The following is a description of a gene set: Human Gene Set: GOBP_REGULATION_OF_VESICLE_MEDIATED_TRANSPORT Any process that modulates the rate, frequency, or extent of vesicle-mediated transport, the directed movement of substances, either within a vesicle or in the vesicle membrane, into, out of or within a cell. studied in species Homo sapiens, and this is the list of marker genes: CCL2, CACNB4, PTPN1, HFE, SNAPIN, ATG5, RIMS2, LYN, APOA1, BVES, DNAJC5, TBC1D5, CASK, RAC2, HLA-F, FCGR1BP, CADPS, SCFD1, IL13, VAMP7, ARAP1, APLNR, C4B, SYT10, MIR185, RAPGEF4, HMGB1, LGALS3, REST, CPLANE2, CCDC32, CBLL1, RAB3C, PRKCA, GAS6, ATP13A2, CALY, AP1G1, HYAL3, SYT6, PRAM1, MCTP1, STAT3, TFR2, DTNBP1, SFRP4, DRD2, DOC2A, LAMP1, STX1A, ARF6, CPLX2, SNF8, DRD4, TUB, ADGRE2, PYCARD, SDC4, UBQLN2, RALA, PIP4P2, PCSK9, BET1L, GPR151, BCR, MSN, FGA, PTX3, ANKRD13A, CNN2 (NCBI Gene Id 1265), ANO6, MYO18A, FCN1, UNC13D, GATA2, APOC1, FCGR2A, PACSIN1, ANXA13, ANKRD27, SIRPB1, TAMALIN, RACK1, C2, RUFY1, DOCK2, PFN2 (NCBI Gene Id 85837), TLR2, PLA2G5, PLCG2, GPC3, KCNB1, STXBP3, EGF, FMR1, RAB31, SV2C, RAB15, TSC2, FGR, APPL1, LETMD1, RAB7A, NR1H2, TOR1A, ATAD1, DLL1, ABCA7, SYT12, GSG1L, AP2S1, CD300A (CD300a molecule), ADIPOQ, PLLP, AP2B1, SH3GL2, EHD1, RAB11A, MAPK3, CLASP2, PDCD6IP, PGAP1, SOD1, RAB5A, PRKCG, SV2B, MIR205, C9orf72, PICK1, ITGB2, CAMK1D, F2RL1, PLD1, PTPN23, ATP2C1, EHD4, SNX33, PRKN, RUFY2, GIT1, RAB4B, CHMP2A, FLOT1, ARHGAP1, SNX4, LGI3, CLEC7A, TSG101, RUFY4, RAB11B, ANGPT1, S100A10, MBTPS1, SNX17, PLA2G3, YIPF5, MIR199A1, CYBA, CD177, MAP2K2, ARRB2, CDK5, RAB29 (RAB29, member RAS oncogene family), RPH3A, SLC11A1, GRIK5 (glutamate ionotropic receptor kainate type subunit 5), ATP2A2, SYT7, PICALM, APOA5 (NCBI Gene Id 93561), ITGA2, IFNG, PPP3CB, NSF, STAM, SYT3, SPACA3 (sperm acrosome associated 3), LILRB1, SPHK2, EXPH5, USH1G, VEGFA, PCLO, LYAR, RAB4A, ANKRD13B, FCER1G, LYPLAL1, CLASP1, ACTB, ITGAM, PLS3, RAP1A, PSEN1, DYNC1LI1, PPT1, GRIPAP1, STAP1, ANKFY1, FCGR1A, LRRTM2, STXBP5, SEPTIN4, USP7, RABGEF1, WDR44, LRPAP1, LRSAM1, DLG4, SEPTIN1, COLEC11, CCR7, FGB, CPLX3, VAMP2, GAS1, EIPR1, RINT1, APOC3, ARHGAP8, CDC42, NEU3, TBC1D4, RUBCN, ATXN2, SGIP1, CADPS2, ATP9A, BIN1, ARFIP1, FCGR2C, VPS28, DKK1, STXBP1, STXBP6, DYSF, IL2RG, LMAN2, TGFB1, UNC119, SNX3, VPS18, HPCA, COMMD1, RSC1A1, NEDD4L (NEDD4 like E3 ubiquitin protein ligase), VAMP8, USP46, FBXL20, PREPL, ZNRF2, DOC2B, TGM2, AZU1, APELA, SLC4A8, ROCK1 (Rho associated coiled-coil containing protein kinase 1), STON1, SIRPA, SYN1, CHMP3, ABCA13 (ATP binding cassette subfamily A member 13), WNT5A, CALR, RSPO1, ARRB1, GAB2, IL15RA, DAB2, SLC30A8, SCRIB, NCKAP1L, CD160, VPS4B, MDM2, CD22, PPFIA2, RNF139, CLIP3, APOA2, SUSD4, RAP1B, CNST, RAB27B, MIR183, ARC, GNAI2, RAB2B, BICD1, LPAR1, STX18, ACTG1, STX4, MTMR2, ZDHHC2, TF, MTMR4, RNF220, CD14, MICAL1, GATA1, MIR17, EZR, SYTL4, ZNRF1, IL4 (NCBI Gene Id 3565), SYT1, SYT9, PPP3CC, WASL, APOE, DENND10 (NCBI Gene Id 404636), SYT8, CALM3, EHD2 (EH domain containing 2), DNAJC13, AHI1, GH1, RAB3D, CFP, SYNJ2BP, CLU, RAB11FIP3, USE1, CCL21, ABL2, EEF2K, USP6, GREM1, SMPD3, AXL, TRPV6, NPY, RAB21, SYT4, OPHN1, PRKAR1B, PARK7, SEPTIN5 (NCBI Gene Id 5413), LRRK2, SIRPG, RIMS3, RABEP1, CSK, CDH13, CD63, AAK1, SPHK1, ARHGDIA, ABCA2, LDLRAP1 (NCBI Gene Id 81862), APP, SYK, RAB3B, ITGAV, AKAP5, RAB3GAP1, CORO1A, PIK3CB, RAC1, CSPG5, PPP3CA, VAC14, MERTK, NLGN1, MIR20A, RAP1GAP, WNT3A, MAGI2, PLA2G4E, CDK5R2, SYT5, SCARB1, SCRN1, CD84, NOTCH1, EPHA3, PLSCR1, ZP3, MIB1, MAPK1, BAIAP3, SNX9, SMPD1, PTPRJ, PACSIN2, LRRTM1, ARPC3, HCK, CD47, ARHGAP44, C3 (complement component 3), ANXA2, NCDN, PRKACA, VTN, CACNA1B, CBL, NUMB, TBC1D20, BTBD9, HGS, AP2A1, FES, MYLK, NRG1, FOXF1, INPP5F, C2CD5, EFNB2, FCGR2B, DNAJC6, CAV3, CBLB, LYSET, RAB37, RAB5B, FCN3, MIR92B, SFTPD, RIMS1, STON2, ARFGAP1, PRRT2, PRKAA1, STX1B, FPR2, ITGB3, STXBP2, RDX, AP2M1, MKLN1, SCAMP5, ADRA2A, PACSIN3, PTPRC, IL1RAPL1, CASP3, ACSL3, RIN3, P2RY1, PPP3R1, RIT2, VPS11, BMP2K, RAB9A, MIR181B1, WDR41, WDR54, C4A, SLAMF1, KLRC2, ZFYVE16, ARF1, MAP2K1, FGG (NCBI Gene Id 2266), RIMS4, ERC2, SNAP91, NDRG4, AHSG, CPLX1, DGKD, TNK2, PDPK1, LRP1, MIR27B (NCBI Gene Id 407019), ABL1, ANXA1, PLD2, ANKRD13D, CAV1, WNT7A, APPL2 (NCBI Gene Id 55198), CBARP, ACTN2 (actinin alpha 2), SERPINE1, CEACAM1, ADORA2B, CLN3, PKDCC, B2M, RAB25, LGALS9, NTF3, FCN2, SYT15, RAP1BL, PROM2, TULP1, TREM2, PRKD1, PRTN3, HIP1, CFTR, TPCN2, SYT17, APOC2, SDC1, CD36, CD300LF, CCL19, ATG3, HAP1, DGKQ, SORL1 (sortilin related receptor 1), BTK (Bruton tyrosine kinase), BSN, SMCR8, IL2RB, NF2, VPS4A, SNCA (NCBI Gene Id 6622), CPLX4, NR1H3, SMAP1, SYT13, IL15, ITSN1, CD151, VSNL1, FERRY3, SYT2, NRP1 (NCBI Gene Id 8829), MBL2, SRC, NECAB2, FBXO45, COLEC10, RAB33B, DVL1, RAB27A, CCR2, RPH3AL, ALOX15, SDCBP, PRKCB, HAMP, SYT11, VAMP4, APLN, SELE, HIP1R, SLC17A7, SNX12 (NCBI Gene Id 29934), RAB3A, BRAF, ANXA2P2, RAB26, LYPLA1, SH3GL3, RAB5C, H1-1, INSR, CHMP6, IL13RA2, IL4R, SPI1, P2RX1 (NCBI Gene Id 5023)